Given this list of marker genes GLB1, GALC, ARSA, ASPA, PSAP, here is a description of the gene set: A type of rigidity that is manifested by an exaggerated extensor posture of all extremities. Human Gene Set: HP_DECEREBRATE_RIGIDITY Decerebrate rigidity studied in species Homo sapiens